Given this list of marker genes Rps7 (ribosomal protein S7), Ndufs5, Lgals1, Aprt, Higd2a, Pfn1, Tmem205, Flt3 (FMS-like tyrosine kinase 3), Bud31 (BUD31 homolog), Acta2, Ndufb7, Rps10, Atp5if1, Cox4i1 (NCBI Gene Id 12857), Ptma, Krt8, Sarnp, Bri3, Smdt1, Mrpl23, Dpm3, Snrpd2, Cryab (crystallin, alpha B), Pfdn5, Dynlrb1, S100a16, Bcl7c, Gadd45g, Rpl26, Mfap2, Selenom, Nhp2, Hspe1, Nedd8, Polr2i, S100a1, Rbm8a, Polr2j, Park7, Phpt1, H2-Aa, Rps14, Gas5, Rpl17, Atp6v1f, S100a13, Il3ra, Fau, Cox6c, C920021L13Rik, Rpl24, 2310033P09Rik, Rpl27a, Cygb, Atp6v0e, Timm13, Snrpd3, Trmt112, Ndufb8, Lyz2, Micos10, Hint1, Cox6a1, Rps15, Micos13, Coq7, Gtf2h5, Fxyd1, Cd74, Rhoc, Ndufs6, Vcf1, Cox6b1, Ifi27, Rpl22l1, Cdkn1c, Magoh, Ndufb10, Snrpg, Rpl34-ps1 (ribosomal protein L34, pseudogene 1), Svbp, Vkorc1, Mif, Rps27, Gng11, Tspo, Rbm25, Sphkap, Cycs, Atf5, Rpl27, Ndufb4, Rplp1, Rarres2, Rps15a, Tmsb10, Ypel3, Psmb2, Fkbp2, Mt1, Cfl1, Myl12a, Fth1, Eif5a, Kdm6b, Gpx1, Mustn1, Rps18, Tmem176a, Saysd1, Map1lc3a, Arpc3, Psmb8, Rpl32, Pcbd2, Uqcrh, Ift27, Ly6a, Cavin3, Atp5mc1, Rpl11, Dctn3, S100a6, Psme1, Pmepa1, Cyba, Wdr83os, Apoe, S100a10, Tppp3, Scand1, Timm8b, Elob, Swi5, Aebp1, Ndufb9, Rps20, Zfp575, Ndufb6, Znhit1, Cuta, Nme1 (NME/NM23 nucleoside diphosphate kinase 1), Zfp36l1, Ndufa5 (NCBI Gene Id 68202), Sertad1, Gpr34, Nme3, Gstm1, Reep5, Ier3, Ift20, Rps24, Oaz1, Fmc1, Rpsa, Ndufa11, Tcf7l2, Rpl36, Atp5pd, Krtcap2, Uqcr11, Clic4, Grcc10, Ndufc2, Rala, Rpl23, Rps19, B2m, Ccdc85b, Atp6v0b, Polr2a, Ndufa7, Rp9, Rpl18a, Sub1, Cox5a, Tle5, Dbi, Tomm5, Rpl22, Dad1, Sec62, Ptms, Rps11, Rps27a, Rabac1 (NCBI Gene Id 80486), Aimp1, Ap2s1, Mir24-2, Ccdc124, Psma7, Pfdn6 (NCBI Gene Id 14976), Gstp1, Ftl1, Mrpl30, Lamtor4, Rpl23a, Rpl41, Ier3ip1, Tomm6, Cox8a, Mrpl33, Ubb-ps, Tpt1, Cops9, Rbis, Srp14, Ddah2, Pdap1, Mrpl48, Mrps24, Rps8, Rbm39, Rps13, Cenpx, Ralbp1, Ssr4, Inmt, Ndufa4l2, Rpl35, Ifitm2, Rpl21, Hepacam2, Tmem256, Calm1, Erh, Rpl18, Rpl36a, Edf1, Rbx1, Eif5b, Rpl14, Bsg, Son, Pfdn1, Mdk, Top1, Rtl8c, Uqcr10, Naca, Chga, Mrps33, Serpinb1a, Polr2g, Eif1b, Gpx4, Mien1, Stx8, Fam162a, Nol7 (NCBI Gene Id 93825), Tmem176b, Rpl28 (ribosomal protein L28), U2af1, Psmb3, Cstb, Rplp2, Tma7, H2az2 (NCBI Gene Id 77605), Myl6, Cox7a2, Hsp90aa1, Rpl6, Copz2, Ndufv3, Ubxn1, Mt2, Aamdc, Bloc1s1, Rps17, H2-Ab1, Arl3, Ppib, Gadd45b, Rpl13a, Ndufc1, Ifitm3, Dynll1, Fis1, Rps5, Cd63, Timp1, Atp5mc3, Pdcd5, H2-Q4, Chchd7, Ndufb11, Rps27l, Tmem160, Fkbp3, Atox1, Lamtor2, Hypk, Sem1, Pdlim2, Psmb4, Atp5f1d, Hmgb1, Anapc11, Rnaseh2c, Pttg1, Nme2, Trir, Tbcb, Tmsb4x, Polr2f, Sec61b, Chmp2a, Mrps21, Map1lc3b, Nop10, Ddrgk1, Rbp1, Cst3, Cald1, Nupr1, Serpinb6b, Gng5, Srrm2, Id3, Atp5po, Serf2, Psmb10, Ndufa6, Pomp, Ncl, Tmem107, H2-Eb1, Kcnj8, Rpl36al, Eny2, Snrpc, Nfkbia, Ndufa13, Polr2l, Crip1, Atp5mg, S100a11, Mrps14, Mfap5, Atp6v0c, Rps9, Cltb, Emp3, Psmb6, Rpl34, Atp5mc2, Mea1, Sde2, Rex1bd, Rpl13, Fdx2, Etfb, 4930523C07Rik, Hcfc1r1, Rnaset2b, Selenow, Romo1, Bst2, Prr13, Igfbp6, Atp5pf, Ndufs7, Atp5mf (ATP synthase membrane subunit f), Rpl31, Cdkn1a, Rpl9, here is a description of the gene set: studied in species Mus musculus Mouse Gene Set: TABULA_MURIS_SENIS_DIAPHRAGM_MESENCHYMAL_STEM_CELL_AGEING from publication Tabula Muris Consortium (PMID 32669714)